The following is a description of a gene set: Mouse Gene Set: GOBP_MITOTIC_CHROMOSOME_CONDENSATION species: Mus musculus The cell cycle process in which chromatin structure is compacted prior to and during mitosis in eukaryotic cells., and this is the list of marker genes: Baz1b, Akap8, Smarca5 (SWI/SNF related, matrix associated, actin dependent regulator of chromatin, subfamily a, member 5), Chmp1a, Ncaph, Ncapg, Akap8l, Ncaph2, Smc4, Smc2, Nusap1, Ncapd2, Atf6b, Ncapd3, Cdca5, Phf13